Given this list of marker genes Helb, Chd7 (chromodomain helicase DNA binding protein 7), Mcm6, Ruvbl2 (NCBI Gene Id 20174), Ercc2, Mcm5, Dhx9 (DExH-box helicase 9), Chd1, Fancm, Hfm1, Mcm9, Mcm4, Chd6, Twnk, Ercc6l, Helq, Fbh1, Ighmbp2, Chd1l, Mcm7, Mcm3, Mcm8, Blm, Mcm2, Recql5, Dqx1, Wrn, Recql4, Chd2, Rad54l2, Chd9, Rad54l, Ruvbl1, Ddx11, Gtf2f2 (NCBI Gene Id 68705), Pif1, Chd4, Rtel1, Ascc3, Chd5, Nav2 (NCBI Gene Id 78286), Smarcad1, Ercc3, Atrx, Recql, Chd8, G3bp1, here is a description of the gene set: species: Mus musculus Unwinding a DNA helix in the direction 5' to 3', driven by ATP hydrolysis. Mouse Gene Set: GOMF_3_5_DNA_HELICASE_ACTIVITY